Given this list of marker genes WDR54, ADIPOQ, MIR27B, LRRTM2, ANXA2, SH3GL3, UBQLN2 (NCBI Gene Id 29978), NEU3, PICALM, LRRTM1, DLG4, B2M, UNC119, ARF6, ANKRD13D, ABCA2, RABGEF1, MIR185, MIR199A1, RIN3, ATXN2, MIR205, PCSK9, MIR17, APOC2, APOC1, LRPAP1, APOC3, ANKRD13B, RAC1, MIR92B, SDCBP, ANKRD13A, NECAB2, MTMR2, here is a description of the gene set: species: Homo sapiens Any process that stops, prevents, or reduces the frequency, rate or extent of receptor mediated endocytosis, the uptake of external materials by cells, utilizing receptors to ensure specificity of transport. Human Gene Set: GOBP_NEGATIVE_REGULATION_OF_RECEPTOR_MEDIATED_ENDOCYTOSIS